Given this list of marker genes Xcl1, Cyrib, H2-D1, Sh2d1a, Serpinb9c, H2-Q4, Fcer2a, H2-M10.6, Slc22a13, Serpinb9d, Crk, Pvr, Ripk3, Sh2d1b2, Serpinb9h, Hsp90ab1, H2-T5, Il23a, Gimap3, P2rx7, 2410137M14Rik, Il4, Il13, Ulbp1, H2-T23, Ap1g1, H60b, Ptprc, Ppp3cb, Nckap1l, Azgp1 (alpha-2-glycoprotein 1, zinc), H2-Q10 (NCBI Gene Id 15007), Clec12b, H2-Ea, H2-M5, Syk, Il21, Klrb1b, Nos2, H2-Q7, H2-M10.4, Klrb1, H60c, B2m, Cadm1, Serpinb9, Dnase1l3, Cr1l, Cd226, Klrb1a, Itgam, Cd1d2, Rasgrp1, Mr1, Serpinb9e, Cxcl1, Cfh (complement component factor h), Fadd, Pik3r6, Raet1d, H2-M2, H2-T3 (histocompatibility 2, T region locus 3), Stap1, Bcl2l11, Lamp1, H2-M10.1, Ccr5, Stx7, Cx3cr1, Arrb2, Bad, Gimap5, Grb2, Ager, Klrc1, Stat5b, H2-M10.2, Clec7a, Pnp, Tyrobp, Arg1, H2-Q6, Inpp5d, Tgfb1, Nectin4, H2-M10.5, Tap2, Klrb1c, Serpinb9g, Il12a, H2-T15, Cd55, Ncr3-ps, Pomc, Cd59a, Cd1d1, Crtam, Mill1, Dnase1, Klrb1f, H2-T13, Klre1, Cd5l, Serpinb9b, Raet1e, H2-M1, Klri1, Lgals9, Stat5a, Sh2d1b1, Vav1, H2-Q2, H2-M9, Klrk1, Tap1, Klrd1, Cxcl5, H2-T24, H2-M10.3, Klrc3, Ifng, Klrc2, Lag3, Serpinb9f, Oga, Klri2, Ccl2, H2-K1, Il12b, Clec2d, Prf1 (NCBI Gene Id 18646), Havcr2, H2-M3, Il7r, Nectin2, Il18rap, F2rl1, Cd59b (CD59b antigen), Ceacam1, H2-M11 (NCBI Gene Id 224754), Muc4, Cd160, Gfer, H2-Q1, Lep, Hspa8, H2-T22, Slamf6, Igf2, Spi1, here is a description of the gene set: studied in species Mus musculus Mouse Gene Set: GOBP_REGULATION_OF_CELL_KILLING Any process that modulates the frequency, rate or extent of cell killing, the process in which a cell brings about the death of another cell, either in the same or a different organism.